Given this list of marker genes Cyp4v3, Adh7, Adh5, Adh4, Cyp4f13, here is a description of the gene set: A fatty acid oxidation process in which the methyl group at the end of the fatty acid molecule (the omega carbon) is first oxidized to a hydroxyl group, then to an oxo group, and finally to a carboxyl group. The long chain dicarboxylates derived from omega-oxidation then enter the beta-oxidation pathway for further degradation. Mouse Gene Set: GOBP_FATTY_ACID_OMEGA_OXIDATION species: Mus musculus